The following is a description of a gene set: species: Mus musculus Mouse Gene Set: GOBP_PEPTIDYL_THREONINE_MODIFICATION The modification of peptidyl-threonine., and this is the list of marker genes: Grk2, Plk1, Prkcd, Chi3l1, Ttbk1, Tbk1, Map3k12, Ube2k (NCBI Gene Id 53323), Cadm4, Cab39, Stk39, App, Pbk, Eogt, Cad, Camk2d, Galnt16 (polypeptide N-acetylgalactosaminyltransferase 16), Hnf1a, Irgm2, Oxsr1, Ttc36, Galnt11, Csnk2b, Dgkq, Cdk1, Spred2, Spred1, Wnk1, Spry2, Gsk3b, Galnt13, Acvr1b, Dmtn (NCBI Gene Id 13829), Hipk3, Eif4g1 (NCBI Gene Id 320196), Ripk2, Camk2a, S1pr2, Wnt5a, Egf (NCBI Gene Id 99717), Ulk1, Mapk1, Prkdc, Sirt2, Ogt, Hipk2, Phip, Pard3, Tssk4, Prkd2, Wnk3, Galnt1, Cdk5, Prkaca, Chek1 (checkpoint kinase 1), Tnks, Adcy10, Ppp1r15a, Umod, Gsk3a, Mylk2, Igtp, Galnt2, Ppp2r5d, Sphk1, Met, Tnks1bp1, Bcl2, Trpc5, Cemip, Rptor, Myo3a, Lrrk2, Ppef2 (NCBI Gene Id 19023), Ttk, Mapk8, Cdk5r1, Myo3b, Map3k10, Akt3, Prkd1, Cdk10, Galntl6, Trim6, Nlk, Irgm1, Mtor, Trpc6, Smad7, Stk11 (serine/threonine kinase 11), Clk1, Prkag2, Stox1, Rock2, Akt1 (thymoma viral proto-oncogene 1), Lmtk2, Galnt4, Galnt3 (polypeptide N-acetylgalactosaminyltransferase 3), Inpp5k, Galnt6